The following is a description of a gene set: species: Homo sapiens Genes having at least one occurence of the motif CTCCAAG in their 3' untranslated region. The motif represents putative target (that is, seed match) of human mature miRNA hsa-miR-432 (v7.1 miRBase). Human Gene Set: CTCCAAG_MIR432, and this is the list of marker genes: CDPF1, CAPN3, HYCC2, RASGRP4, CELSR2, CPEB2, TMEM245, ANKRD28, SLMAP, HIF1AN, AGO1, PITPNC1 (phosphatidylinositol transfer protein cytoplasmic 1), ABCC3, TOX4, AMFR, PDE1B, STRADA, PHLPP2, HOXA5, FNTB, BACE1, ARL5B, CAVIN2, SPARC (NCBI Gene Id 6678), CRB3, CPT1B (NCBI Gene Id 150414), BRPF1, ZNF503, ABCA9, TLN1, KCNH5, PDE4A, GRIA2, DAB2IP, INO80C, EHD3, FDX2, ACE, HSPA14, PRP4K, PURA, GARRE1, FURIN, TRIM9, TRPC3, TSHZ3, CSE1L, TBC1D22B, SPTY2D1, SMCR8, EML4, FAM171A1, NHSL3, NFAT5, PLAGL2, VGLL3, ESRRA, FN1, SRSF1, AKIRIN1, POLE3, ALKBH8, CA3, HMGA2, AP3S1, ZFP91, STK35, PDLIM5, LUZP1, KDM5C (NCBI Gene Id 8242), ANKZF1, VXN, NR5A2, PSD3, POLDIP2, RGS7BP, NSD2, RNF44 (NCBI Gene Id 260352), DCTN3, PMP22, CHKB, EEF1DP3, HOMER2 (NCBI Gene Id 9455)